The following is a description of a gene set: Genes translationally repressed by rapamycin (sirolimus) in MEF cells (embryonic fibroblast) lacking either TSC1 or TSC2 but not in the wild type cells. Mouse Gene Set: BILANGES_RAPAMYCIN_SENSITIVE_VIA_TSC1_AND_TSC2 species: Mus musculus The tuberous sclerosis complex (TSC) proteins TSC1 and TSC2 regulate protein translation by inhibiting the serine/threonine kinase mTORC1 (for mammalian target of rapamycin complex 1). However, how TSC1 and TSC2 control overall protein synthesis and the translation of specific mRNAs in response to different mitogenic and nutritional stimuli is largely unknown. We show here that serum withdrawal inhibits mTORC1 signaling, causes disassembly of translation initiation complexes, and causes mRNA redistribution from polysomes to subpolysomes in wild-type mouse embryo fibroblasts (MEFs). In contrast, these responses are defective in Tsc1(-/-) or Tsc2(-/-) MEFs. Microarray analysis of polysome- and subpolysome-associated mRNAs uncovered specific mRNAs that are translationally regulated by serum, 90% of which are TSC1 and TSC2 dependent. Surprisingly, the mTORC1 inhibitor, rapamycin, abolished mTORC1 activity but only affected approximately 40% of the serum-regulated mRNAs. Serum-dependent signaling through mTORC1 and polysome redistribution of global and individual mRNAs were restored upon re-expression of TSC1 and TSC2. Serum-responsive mRNAs that are sensitive to inhibition by rapamycin are highly enriched for terminal oligopyrimidine and for very short 5' and 3' untranslated regions. These data demonstrate that the TSC1/TSC2 complex regulates protein translation through mainly mTORC1-dependent mechanisms and implicates a discrete profile of deregulated mRNA translation in tuberous sclerosis pathology. from publication Bilanges B, Argonza-Barrett R, Kolesnichenko M, Skinner C, Nair M, Chen M, Stokoe D (PMID 17562867), and this is the list of marker genes: Gm6607, Bri3bp, Cct4, 2810025M15Rik (RIKEN cDNA 2810025M15 gene), Hspa8, Impdh2, Rps21 (NCBI Gene Id 76519), Gtpbp6, Cnih1, Rps26, Tubb2a, Atp5f1a, Bgn, Blvrb, Nap1l1, Rpl36al, Tcp1, Nudt21, Ola1, Vdac1, Gapdhs, Tomm20, Entpd3, Cs, Zkscan17, Prcp, Serpinb6c, Hnrnpa1, Acbd6, Polr1c, Nol3, Rpl31, Eif3k, Mrpl30, Fxr1, Kdelr1, Slc25a3, Vim, Paics, Tubb5 (NCBI Gene Id 319597), Rps28, Ssr4, Tspan15, Igbp1, Nme2, Rpl35a, Rpl36, Aimp1, Eif3e, Gyg1, 4930519F09Rik, Uqcrfs1, Bcs1l, Tcp1-ps1, Rpl3, Cryz, Rph3al, Btf3, Eif2s3x, Atp6v1g2, Rtraf, Slc25a17, Psat1, Naa10 (N(alpha)-acetyltransferase 10, NatA catalytic subunit), Rpl10a, Tubb4a, Cct2, Acot1, Nsa2, Prdx3, Ahcy (NCBI Gene Id 98842), Slc25a5, Serpinb6a, Ppm1g, Ppib